The following is a description of a gene set: species: Mus musculus The process of causing a cell to become susceptible to natural killer cell mediated cytotoxicity. Mouse Gene Set: GOBP_SUSCEPTIBILITY_TO_NATURAL_KILLER_CELL_MEDIATED_CYTOTOXICITY, and this is the list of marker genes: Pvr, Ulbp1, Nectin2, Cadm1, Raet1d